Given this list of marker genes NFKBIA, TNFRSF21, RC3H2, VTCN1, IGHG4 (immunoglobulin heavy constant gamma 4 (G4m marker)), CARD11, PIK3CA, BCL10, ZC3H12A (NCBI Gene Id 80149), NCK1, VAV3, RELA, PHPT1, KCNN4, ABL1, CACNB3, TRAC, BTN2A1, STAP1, BCL2, MIR19A, RPS3, CTLA4, CD247, PVRIG, FYN, IGHG1, MS4A1, CBLB, TRGC1, NFAM1, SLA2, HLA-DRB1, RAB29, PIK3CD, BTN3A2, LPXN, LAT, CD72, BMX, EZR, DUSP22, TRBC2, HLA-DPB1, BTRC, HLA-A, CD8A, DENND1B, IGLC1, TRAT1 (T cell receptor associated transmembrane adaptor 1), MIR34A, IGHG3, BTNL9, INPP5D (inositol polyphosphate-5-phosphatase D), RFTN1, TRGC2, CD19, FOXP3, ZAP70, GPS2, ELF1, SKAP1, IKBKB, EIF2B2, FCGR2B, MAP3K7, IGHD (immunoglobulin heavy constant delta), BAX, NFKBID, WNK1, KLHL6, BRAF, CD2AP, FOSL2, CD3E, PTPN6, GCSAML, IGHA1, TESPA1, SIVA1, PTPRJ, BLNK, CD79B, PAWR, NCKAP1L, GBP1, PTPN2, SYK, UBE2N, IGHA2, LAT2, EIF2B1, BTN1A1, CEACAM1, MIR18A, IGHE, LGALS3, CYLD, SOS1, BTN2A3P, SPG21, ITK, DUSP3, MOG, GCSAM, CMTM3, BANK1, MNDA, FYB1, EIF2B4, UBASH3A, CD81, LCP2, HLA-DRB3, PRKCH, ITPRIPL1, PDE4D, RBCK1, THY1, FCRL3, TRBC1, CD3D, ICOSLG, IGLC3, LAPTM5, SH2D1A, BLK, PLEKHA1, RNF31, PRNP, BTNL3, PLCL2, CD300A, ERMAP, CD8B, SPPL3, EIF2B3, BTNL8, EIF2B5, LIPA, PTPRC, LIME1, BTN3A3, LAX1, THEMIS, SHB, THEMIS2, ADA, RC3H1, CD3G, LCK, FCHO1, SLC39A6 (solute carrier family 39 member 6), CD276 (CD276 molecule), NFKBIZ, BTN3A1, MALT1, MAPK1, PLCG2 (phospholipase C gamma 2), BTNL2, HHLA2, KHDRBS1, IGLC6 (NCBI Gene Id 3542), GATA3, MEF2C, IGHM, BCAR1, SLC39A10, DGKZ, CD38, TEC, HLA-DQB1, CD226, PRAM1 (NCBI Gene Id 84106), PTPN22, CRKL, RIPK2, CD22, HRAS, NECTIN2, BTNL10P, IGKC, CACNB4, PSEN1, BTK, IKBKG, UBR2, LYN, LILRB4, FOXP1, TRDC, STK11, CD160, PRKCB, NFKB1, SH2B2, PRKD2, TXK, FYB2, PLCG1, FCMR, CSK, CD79A, TRAF6, IGHG2, CD28, NFATC2, CCR7, IGLC7, ZNF683, BTN2A2, STOML2, GRB2, PDE4B, here is a description of the gene set: species: Homo sapiens Human Gene Set: GOBP_ANTIGEN_RECEPTOR_MEDIATED_SIGNALING_PATHWAY The series of molecular signals initiated by the cross-linking of an antigen receptor on a B or T cell.